Given this list of marker genes Gjb2, Gjd3 (NCBI Gene Id 353155), Tubb6, Tubal3, Gja3, Tubb4a, Tuba1c, Gja4, Tuba3b, Tuba4a, Cltb, Gjb4, Gjb5, Tuba1a, Tubb4b, Ap2m1, Tuba1b, Gja1, Gjd2, Tubb2b, Tuba8, Dnm2, here is a description of the gene set: electronically inferred by orthology from the curated human pathway part of: Membrane Trafficking Reactome Pathway: Gap junction trafficking and regulation This event has been computationally inferred from an event that has been demonstrated in another species.<p>The inference is based on the homology mapping from PANTHER. Briefly, reactions for which all involved PhysicalEntities (in input, output and catalyst) have a mapped orthologue/paralogue (for complexes at least 75% of components must have a mapping) are inferred to the other species. species: Mus musculus